The following is a description of a gene set: Human Gene Set: GOBP_MESENCHYME_MIGRATION The process in which the population of cells that make up a mesenchyme undergo directed movement. species: Homo sapiens, and this is the list of marker genes: ACTC1, ACTA2 (actin alpha 2, smooth muscle), ACTG2, ACTA1, FOXF1